The following is a description of a gene set: species: Homo sapiens Any process that results in a change in state or activity of a cell or an organism (in terms of movement, secretion, enzyme production, gene expression, etc.) as a result of an interleukin-4 stimulus. Human Gene Set: GOBP_RESPONSE_TO_INTERLEUKIN_4, and this is the list of marker genes: CITED1, IMPDH2 (inosine monophosphate dehydrogenase 2), PTPN2, STAT5B, CORO1A, IL4R, DCSTAMP, CCL11, RPL3 (ribosomal protein L3), JAK1, KEAP1, JAK3, ADAMTS13, ALAD, NFIL3, RUFY4, IL4, CD40, MCM2, STAT6, XBP1, IL2RG, FASN, HSP90AB1, XCL1, HSPA5, PARP14 (poly(ADP-ribose) polymerase family member 14), LEF1, IL24, TCF7, MRC1, SHPK, TUBA1B, STAT5A, PTPRC, CD300LF, CDK4, PML, GATA3